The following is a description of a gene set: Signaling mediated by p38-alpha and p38-beta Human Gene Set: PID_P38_ALPHA_BETA_DOWNSTREAM_PATHWAY species: Homo sapiens from publication Schaefer CF, Anthony K, Krupa S, Buchoff J, Day M, Hannay T, Buetow KH (PMID 18832364), and this is the list of marker genes: PPARGC1A, RPS6KA4, MAPK14, MEF2C, MKNK1, CEBPB, HSPB1, RPS6KA5, PTGS2, KRT19, CSNK2B, PLA2G4A, MAPKAPK2, DDIT3, EIF4EBP1, MAPK11, TP53, RAB5A, MITF, JUN, ELK4, KRT8, SLC9A1, MEF2A, ATF6, HBP1, EIF4E, CSNK2A2, NOS2, MAPKAPK5, CSNK2A1, ATF1, ATF2, CREB1, GDI1, MAPKAPK3, ESR1, USF1